Given this list of marker genes DUSP1, DUSP5, DUSP18, PPP5C, PPM1B, PDP1, PPM1E, PPM1D, PPP2CA, PPM1G, here is a description of the gene set: Human Gene Set: GOBP_PEPTIDYL_THREONINE_DEPHOSPHORYLATION The removal of phosphoric residues from peptidyl-O-phospho-L-threonine to form peptidyl-threonine. species: Homo sapiens